The following is a description of a gene set: EEG abnormalities (epileptiform discharges) evoked by flashing lights or black and white striped patterns. Human Gene Set: HP_EEG_WITH_PHOTOPAROXYSMAL_RESPONSE EEG with photoparoxysmal response species: Homo sapiens, and this is the list of marker genes: GABRA1, SHQ1, FBXO28, CERS1, STARD7, MARCHF6, SAMD12